Given this list of marker genes Cnpy4, Ywhag, Chst12, Tmem184a, Dnajc30, Mmd2, Gm4963 (NCBI Gene Id 243302, predicted gene 4963), Abhd11, Gpc2, Ppp1r35 (protein phosphatase 1, regulatory subunit 35), Mir7037, Mir721, Ccz1, Gm42808, Ache, Gm7291, Arpc1a, Mblac1 (NCBI Gene Id 330216), Mepce, Gm26970, Syna, Cyp3a63-ps, Zfand2a, Lrch4, Orai2, Por, Castor2, Trim50, Gnb2, Gm36667, Cyp3a57, C230071H17Rik, Gm10051, Trrap, Mad1l1, 9430007M09Rik, Lamtor4, Mir6418, Gm10369, Pilra, Cox19, Cyp3a11, Gm4870, Irs3, Gm10874, Spdye4b, Gm15672, Gm22956, Ap5z1, Pdap1, Dtx2, Muc17, Gper1, Gm454, Vgf, Zdhhc4, Gm15607, Cyp3a44, 4930520M14Rik, Kdelr2 (NCBI Gene Id 66913), Znhit1, Gtf2ird2, Daglb, 9030607J07Rik (RIKEN cDNA 9030607J07 gene), Mir7036, Zp3 (NCBI Gene Id 22788), Kpna7, 6330403L08Rik, Cyth3, Clip2, Muc3a, Sun1, Wipi2, Agfg2 (ArfGAP with FG repeats 2), Rcc1l, Mir7228 (NCBI Gene Id 102465708), Mrm2 (mitochondrial rRNA methyltransferase 2), Or10ah1-ps1, Cyp2w1, Gm7902, Dnaaf5, Gm20768, Fbxl18, Fis1, Cldn4, Ufsp1, Gm8454, Vps37d, Taf6, Rfc2, Slc29a4, Cyp3a25 (NCBI Gene Id 56388), Gm16061, Rhbdd2, Aimp2, Gm20605, Plod3, Prkrip1, Rps29-ps, Gm43013, Cux1, Upk3b, Gm26989, D130017N08Rik, 6330418K02Rik, Lmtk2, Slc12a9, Gm25492, Cyp3a13, Mospd3, Ift22, BC030343, Tmem120a, Gm16121, Bri3, Gm6433, Srrm3, Lfng, Srrm3os, Fkbp6, Gm5564, Gm43380, Polr2j, Psmg3, Gm6272, Baiap2l1, Zkscan5, Alkbh4, 2610011E03Rik, Sh2b2, Smurf1, Usp42, Pilrb2, Zfp68, Gm15770 (NCBI Gene Id 677204), Col26a1, Gm36266, Dmrt1i, Ephb4, Gm40348, 2810432F15Rik, Eln, A430033K04Rik, Smok3a (NCBI Gene Id 545814), Gm16089, Abhd11os, Gm8099, Styxl1, Rasa4, Auts2, Baz1b, Ttyh3, Zscan21, 4933439J24Rik, Gm17979, Zkscan1, Galnt17, D430018E03Rik, Cops6, Kif19b, Fam220a, Gal3st4, Selenok-ps7, Prkar1b, Smok3c, Gm9497 (predicted gene 9497), Ccl24, Mir93, Rnf216, Ocm, Sp110-ps2, Ap1s1, 4930500L23Rik, Gm15627, Actb (actin, beta), Trappc14, Mir3965, Gm23995, Grid2ip, Gm16599, Gm43615, Gm29681, Gm5050, Zan, Gm15708, Nptx2, Mir7039, Pdgfa, Cldn15, Zcwpw1, Bcl7b, Tecpr1, Mir702, Gm26925, Gm17112, 3110082I17Rik, Gm15497, Gm9710, Limk1, 9130604C24Rik, Sap25, Pop7, Wbscr25 (Williams Beuren syndrome chromosome region 25 (human)), Eif2ak1 (NCBI Gene Id 15467), Bhlha15, Gm7284, Bud31, Sdk1, Mir7034, Mir8116, Mir7038, Ints15, A430110C17Rik, Spdye4a, 0610040B10Rik, Tbl2 (transducin (beta)-like 2), Papolb, 4933404O12Rik, Cyp3a41b, Gjc3, Muc12, Ints1, Gm30003, Brat1, Nxpe5, Pcolce (NCBI Gene Id 18542), Mlxipl, Gm16020, Actl6b, Ccl26, Srrt, Gm16035, Lrwd1, Rbak, Fzd9, Gtf2ird1, Amz1, Nyap1, Smok3b, Fam20c (NCBI Gene Id 97210), 9530056K15Rik, Zfp113, Pvrig-ps, Cldn3, Card11, Gm19089, Gna12, Ap4m1, Rac1, Mafk, Cyp3a41a, Pvrig, Smim10l3, Iqce, Lat2, Nsun5, Gpr146, Gm22618, Mir339, Cpsf4, Gigyf1, Upk3bl (NCBI Gene Id 69665), Tmem270, 2900089D17Rik, Ptcd1, Gm3103, Gm32158, Azgp1, Snx8, Eif3b, Mir7033, Zfp853, Grifin, Stag3, Gm31274 (predicted gene, 31274), Rpl36-ps9, Gm20485, Zfp157 (zinc finger protein 157), Uncx, Mir7035, Ncf1, Hspb1, Tfr2, Ssc4d, Trip6, 1700030N18Rik, Get4, Gm24131, Foxl3, C130050O18Rik, Mettl27, Gm43649, Tmem130, Myl10, Gm8066, Bud23, Tsc22d4, Cldn13, Fbxo24, Elfn1, Vmn2r-ps24, Gm2314, Zfp655, Radil, Rbakdn, Nudt1, Gm16036, Adap1, Pms2, 4930563F08Rik, Micall2, Mir25, Gtf2i, Mdh2, Gm4871, 1700123K08Rik, Ankrd61, Zfp316 (zinc finger protein 316), Cyp3a16, Mir106b, Pom121, Zfp12, Fscn1, Gm15498, Gm17135, Cyp3a61-ps1, Got2-ps1, Arpc1b, Pilrb1, Zkscan14, Mcm7, Zscan25, Foxk1, Epo, Hip1, 2700029L08Rik, Stx1a, Serpine1, Gm16120, 1700018F24Rik, Gm7285, Gm2404, Gm36551, 4930448H16Rik, Trim56, Atp5mf, Tnrc18, Eif4h, here is a description of the gene set: Mouse Gene Set: chr5G2 species: Mus musculus